Given this list of marker genes TRIM32, C8orf88, ZMYND8, MBNL1, C1orf105, GSTA3, RGPD5, FABP4, PPP1R12A, RAD23B, TNNI3K, OBI1, PDIA5, SLC25A51P1, TRADD, AVIL, ADGRE1, ARFIP2, here is a description of the gene set: Genes up-regulated by TSA alone, with non-hypermethylated promoters, in RKO cells (colorectal cancer). studied in species Homo sapiens from publication Suzuki H, Gabrielson E, Chen W, Anbazhagan R, van Engeland M, Weijenberg MP, Herman JG, Baylin SB (PMID 11992124) Aberrant hypermethylation of gene promoters is a major mechanism associated with inactivation of tumor-suppressor genes in cancer. We previously showed this transcriptional silencing to be mediated by both methylation and histone deacetylase activity, with methylation being dominant. Here, we have used cDNA microarray analysis to screen for genes that are epigenetically silenced in human colorectal cancer. By screening over genes, we show that our approach can identify a substantial number of genes with promoter hypermethylation in a given cancer; these are distinct from genes with unmethylated promoters, for which increased expression is produced by histone deacetylase inhibition alone. Many of the hypermethylated genes we identified have high potential for roles in tumorigenesis by virtue of their predicted function and chromosome position. We also identified a group of genes that are preferentially hypermethylated in colorectal cancer and gastric cancer. One of these genes, SFRP1, belongs to a gene family; we show that hypermethylation of four genes in this family occurs very frequently in colorectal cancer, providing for (i) a unique potential mechanism for loss of tumor-suppressor gene function and (ii) construction of a molecular marker panel that could detect virtually all colorectal cancer. Human Gene Set: SUZUKI_RESPONSE_TO_TSA